Given this list of marker genes Cd200r4, Zfp871, Kdm3a, Abcd3, Pikfyve, Lonrf1, Usp9x (ubiquitin specific peptidase 9, X chromosome), Tmpo, Pfkfb2 (NCBI Gene Id 75925), Gpr22, Rbm24, Nmrk1, Mllt3, Pum2, Nkx2-1, Itsn1, Dapk1, Zswim6, Pde3a, Atad5, Prkd1, Nus1, Ldlrad3, Pcdh19, Vps45, Kitl, Adgre4, Prkaa1, Lbh, Cks2, Sec22c, Inpp4b, Lrch2, Xrn2, Arid1b, Tmprss12, Taok1, Lypd6, Iffo2, Wdfy3, Xlr, Cggbp1, Tmcc1, Macc1, Zfp638, Pitpnb, Kif13a, Cnep1r1, Ppp6r3, Chst14, Ifi204, Rab11fip3, Ppp2r3d, Ppp1r9a, Sgcd, Pum1, Fstl5, Zfp941, Cyp2c38, Trp63, Mex3d, Fam228b, Hspa14, Nog, Shroom2, P2ry12, Sycp2, Twist2, Rbm15, Kdm5c, Pdhx, Kcna2, Synj1, Spcs3, Gsk3b, Aadacl3, Pmepa1, Ereg, Hs3st1, Pate9, Hnrnpr, Ttc7, P2ry10b, Uba2, Rab6b, Foxn2, Arl5a, Zmat1, Chic1, Sdad1, Mecp2, Pcdh18, Bmp1, Npas3, Cdc73, Psph, Igfbp1, Tbc1d12, Trp53inp2, Dennd1b, Ncf1, Acsl4, Ube2b, Cdkl4, Aak1, Senp7, Ncoa2, Plag1 (NCBI Gene Id 56711), Stk17b, Pitx2, Stxbp3, Klf8, Naa15, Tcf7l2, Dtd1, Zmiz1, Hipk1, Slc28a3, Slc35e1, Mfsd2b, Prdm1 (NCBI Gene Id 12142), Parg, Klhl9, Col24a1, Marchf6 (membrane associated ring-CH-type finger 6), Col4a1, Ireb2, Clstn1, Dnajc27, Iws1, Atad1, Ugcg, Axin2, Trappc6b, Rab3c, Rai1, Oas3 (NCBI Gene Id 246727), Ccnl1, Usp34, Snx12, Mef2d, Mmp11, Gtpbp10, Prom1, Smg8, Pten, Metap2, Ino80d, Syngr3, Pkp1, Mmd, Enpp2, Tmem170b, Lrif1, Col19a1, Dhx40, Malt1, Txlng, Scnn1g, Slc4a7, Eif1ad4, Dnajc1, Pdgfc, Tshz1 (NCBI Gene Id 70498), Foxg1, Raph1, Tgfbr1, Rev3l, Luc7l3, Map3k8, Uri1, Adam9, Baz2b, Ubtf, Tank, Coch, Rabgap1, Ascl1 (achaete-scute family bHLH transcription factor 1), Slfn9, Chrdl1, Kcnh5, Daam1, Wee1, Nr4a1, Gas7, Scai, Casz1, Phf13, Kif27, Nedd9, Gucy1b1, Prr5l, Cdkl2, Extl3, Fhip2a, Slc12a2, Epha7, Arhgef9, Tsc22d2 (NCBI Gene Id 74514), Psd3, Fbxl17, Sos1, Tshz3, Slc6a19, Tmem33, Hoxd3, Timm10, Sdc2, Egr3, Rras2, P2ry1, Aggf1, Ube2h, Reps2, Kansl1l, Fgf12, Clasp2, Seh1l, Cdc14a, 5730409E04Rik, Klhl13, Tm6sf1, Scn2a, Gabrb3, Denr, Jag1 (jagged 1), Gfra2, Rnf19b, Gli3 (NCBI Gene Id 14634), Slc6a6, Akap9, Brdt, Donson, Adamts15, Bag4, Dnm1l, Nup133, Jrkl, Ubr3, Txlnb, Grb2, Erp44, Thbs2, Gls, Pes1, Edem3, Cxadr, Hecw1, Slc30a7, Foxf1, Dst, Ccnb2, Ythdc2, Ctdsp1, Agtr1b (angiotensin II receptor, type 1b), Cltc, Wdr37, Cnot7, Gabrb2, Zc3h7b, Zic4, Pkib, Hacd3, Lamtor3, Hmx2, Adam2, Fbxo11, Whamm, Cdc7, Pgap1, Stard8 (NCBI Gene Id 236920), Fam43a, Txndc9, Pdcl, Hfm1, Ctnnd2 (NCBI Gene Id 18163), Chek1, Pgr15l, Mcam, Hycc2, Tmem161b, Zfp11, Pcsk2, Trp53inp1, Ddx19a, Tead3, Tmem245, Taok3, Col1a1, Nfat5, Lrrtm2, Ccnt2, Npat, St7, Pgm2l1, Tpgs2, Tbr1, Fam184a, Rnf220, Lhfpl4, Cyria, Klf6, Csnk2a1, Pxk, Mef2c, Syt1, Epha5, Plk4, Ciart, Akap10, Hnrnpa3, Lemd3, Tent4b, Ssbp2, Slc8a1, Agfg1, Rbbp5, Hsph1, Acyp1, Hsp90b1, Bcl6, Dcaf5, Yipf4, Nr1d2, Klhl2, Mgam, Ube2e3, Ash1l, Dennd4c, Ubr1, Slc1a2, Dgkd, Arhgef38, Cyld, Golt1a, Adamts5, Btbd3, Rnf44, Slit3, Zfp711, Usp1, Slc23a2, Smim13, Cep192, Rab9, Slc7a14, Phf20l1, Dido1, Lratd1, Mrpl44, U2surp, Cts8, Macf1, Btnl9, Slc2a4, Cadm2, Igf1r, Ss18l1, Pappa, Stat5a, Ano9, Mtmr12, Or51l4, Mosmo, Rnf217, Msn, Dmxl1, Vwa5a, Paip1, Cmtr2, Dcun1d4, Mecom, Pex3, Cep135, Col25a1, Adcyap1, Slc38a2, Cdkn1b, Blzf1, Dock3, Tc2n, Hdac9, Nedd1, Tnrc6b, Ankrd44, Ndrg4, Mon2, Cdk12, Egr2, Herc1, Rbfox1, Ect2, Qrich1, D430041D05Rik, Mmrn1, Gm6377, Frmpd4, Ptprk, Rmnd5a (NCBI Gene Id 79046), Cnot6, Nova1, Ccdc82, Zmym5, Pja2, Zcchc24, Ube4a, Ptpn9, Mef2a, Agps, Srsf10, Rbm5, Pde3b, Mettl9, Id2, Tasp1, Cnot2 (CCR4-NOT transcription complex, subunit 2), Zfp804a (zinc finger protein 804A), Il20, Slc16a1, Gpr155, Cdkn2aip (CDKN2A interacting protein), Kank4 (KN motif and ankyrin repeat domains 4), Ogfrl1, Tfcp2l1, Cnot6l, Rab14, Slc35f5, Slc16a10, Zdhhc11, Hmcn1, Vkorc1l1, Birc6, Onecut2, Tmem196, Slc7a6, Cd200r1, Slfn8, G3bp2, here is a description of the gene set: from publication Chen Y, Wang X (PMID 31504780) studied in species Mus musculus Mouse Gene Set: MIR_466F_3P Genes predicted to be targets of miRBase v22 microRNA mmu_miR_466f_3p in miRDB v6.0 with MirTarget v4 prediction scores > 80 (high confidence targets).